Given this list of marker genes Piwil1, Prm1, Tbpl1, Prm2, Bcl2l2, Tdrd1 (NCBI Gene Id 83561), Pygo2, Krt9, H1f7, Tnp2, Crem, Styx, Cib1, Prnd, Camk4 (NCBI Gene Id 52876), Ube2b, Hip1, Parp2, Ybx2, Cadm1, Rnf17, Map7, Pank2, Ip6k1, Fndc3a, Six5, Ppp1cc, Lmtk2, Adamts2, Pafah1b1, Slc12a2, Spmap2, Tnp1, Ddx25, Celf1, Pacrg, Slc4a2, here is a description of the gene set: from publication Matzuk MM, Lamb DJ (PMID 18989307) Mouse Gene Set: MATZUK_SPERMATID_DIFFERENTIATION Genes important for spermatid differentiation, based on mouse models with male reproductive defects. studied in species Mus musculus Reproduction is required for the survival of all mammalian species, and thousands of essential 'sex' genes are conserved through evolution. Basic research helps to define these genes and the mechanisms responsible for the development, function and regulation of the male and female reproductive systems. However, many infertile couples continue to be labeled with the diagnosis of idiopathic infertility or given descriptive diagnoses that do not provide a cause for their defect. For other individuals with a known etiology, effective cures are lacking, although their infertility is often bypassed with assisted reproductive technologies (ART), some accompanied by safety or ethical concerns. Certainly, progress in the field of reproduction has been realized in the twenty-first century with advances in the understanding of the regulation of fertility, with the production of over 400 mutant mouse models with a reproductive phenotype and with the promise of regenerative gonadal stem cells. Indeed, the past six years have witnessed a virtual explosion in the identification of gene mutations or polymorphisms that cause or are linked to human infertility. Translation of these findings to the clinic remains slow, however, as do new methods to diagnose and treat infertile couples. Additionally, new approaches to contraception remain elusive. Nevertheless, the basic and clinical advances in the understanding of the molecular controls of reproduction are impressive and will ultimately improve patient care.